Given this list of marker genes Sult2b1, Sult1b1, Sult1c1, Sult2a6, Sult2a5, Enpp1, Sult2a8, Sult1e1, Sult2a2, Sult2a1, Papss2, Sult2a7, Papss1, Sult2a4, Sult2a3, here is a description of the gene set: studied in species Mus musculus Mouse Gene Set: GOBP_PURINE_NUCLEOSIDE_BISPHOSPHATE_METABOLIC_PROCESS The chemical reactions and pathways involving a purine nucleoside bisphosphate, a compound consisting of a purine base linked to a deoxyribose or ribose sugar esterified with one phosphate group attached to each of two different hydroxyl groups on the sugar.